The following is a description of a gene set: studied in species Homo sapiens Binding to a CCR1 chemokine receptor. Human Gene Set: GOMF_CCR1_CHEMOKINE_RECEPTOR_BINDING, and this is the list of marker genes: CCL4, CREB3, CCL5 (NCBI Gene Id 8147), CCL23, CCL7, CCL3